The following is a description of a gene set: studied in species Homo sapiens from publication Chen Y, Wang X (PMID 31504780) Human Gene Set: MIR12125 Genes predicted to be targets of miRBase v22 microRNA hsa-miR-12125 in miRDB v6.0 with MirTarget v4 prediction scores > 80 (high confidence targets)., and this is the list of marker genes: EPHB6, ATP8B4, FAR2, LPAR5, YPEL2, GIMAP6, ZNF558, PPP3R1, SAMD4A, ZNF420, ISM1, OR51E2, PDE4D, MLEC, TNRC6B, KCNK17, LAMA5, MTMR6, HOXB3, SCUBE2, CNIH1, PDE7B (phosphodiesterase 7B), PSMF1, WDR37, KIAA0232 (KIAA0232), SLC17A4, BAMBI, CCDC88A, SNX20 (sorting nexin 20), ZNF596, ASRGL1, GJA1, SH2D4B, ZNF711, NDUFC1, ZKSCAN5, ZNF532, ARHGDIB, CASP3, ZKSCAN4, IBTK, DNAJB9, TRIM37, NPAT, PDE4B, INSR, CXCL12, RORA, KIAA1328, ENPP1, ATP5PB, CST11, CSGALNACT2, EFTUD2, DCX, GPATCH11, NUAK1, ATP8B2, SPAG11B (sperm associated antigen 11B), MMP10, TARDBP (NCBI Gene Id 81927), ZNF90, PAQR5, ZNF322, FAM53B, EIF2S1, ADGRF1, ITGA4, ANOS1, SLCO1A2, DPH6, SIX2, MKLN1, PGF, RNF213, HIPK1, IDI1, LONRF1, MBOAT1 (membrane bound O-acyltransferase domain containing 1), ZNF12, UGCG, TMEM163, C17orf75, CPEB2 (cytoplasmic polyadenylation element binding protein 2), TRMT10B, SPRYD7, PPARGC1B, RPS6KA3, TMOD2, YAF2, ATXN2L (NCBI Gene Id 11273), MLLT6, CA3, COX4I1, MYLK2, TMTC2, TM2D1, EDC3, SH3PXD2A, UBE2V1, AFF1 (ALF transcription elongation factor 1), DTNA (dystrobrevin alpha), TPM3, NEURL1B, LTN1, SPRED3, EIF4E2